The following is a description of a gene set: species: Mus musculus Mouse Gene Set: GOBP_PROSTANOID_METABOLIC_PROCESS The chemical reactions and pathways involving prostanoids, any compound based on or derived from the prostanoate structure., and this is the list of marker genes: Avp, Akr1c12, Pla2g4a, Ptgr1, Acox1, Il1b, Daglb, Cyp2s1, Akr1c14, Akr1c13, Ces2a, Pla2g2a, Fabp5, Akr1b1, Plaa, Anxa1, Akr1b7, Prxl2b, Tnfrsf1a, Pdpn, Ptgs1, Ces2h, Ptges2, Akr1c21, Ces2b, Gstm1, Akr1c18, Akr1c20, Sirt1, Mgst3, Ptges3-ps, Ces2f, Cthrc1, Gstp2, Gstm3, Akr1c19, Gstm6, Pnpla8, Avpr1a, Pla2g3, Ptges3, Ces2g, Mif, Pla2g10, Ces2e, Akr1c6, Sco1, Gstp-ps, Atp6v1b1 (ATPase, H+ transporting, lysosomal V1 subunit B1), Ptgr2, Mapk9, Gstp1, Pla2g4f, Ptgis, Pibf1, Edn1 (endothelin 1), Sphk1, Hpgds, Ces2c, Tbxas1, Ptges, Cd74, Hpgd, Edn2, Akr1cl, Ptgds, Gsta1, Comt, Ptgs2, Gstp3